Given this list of marker genes Fbxo45, Nfib, Draxin, Plxna4, Wdr47, Nr2e1, Bhlhe22, Tsku, here is a description of the gene set: Generation of a long process of a CNS neuron, that carries efferent (outgoing) action potentials from the cell body in one half of the cerebral cortex towards target cells in the contralateral half. This axonal process is a member of those that make up the anterior commissure, a small midline fiber tract that lies at the anterior end of the corpus callosum. Mouse Gene Set: GOBP_ANTERIOR_COMMISSURE_MORPHOGENESIS species: Mus musculus